The following is a description of a gene set: Any process that modulates the frequency, rate or extent of bone mineralization. species: Homo sapiens Human Gene Set: GOBP_REGULATION_OF_BONE_MINERALIZATION, and this is the list of marker genes: FAM20C, TXLNG, COMP, FBN2 (fibrillin 2), VDR, WNT4, PTN, ACVR2B, TMEM119, OSR1, ACVR2A, SRGN, PTH, NOTUM, BMP6, STATH, ACTN3, TRPM4, BMP2K, CCR1, GPM6B, GATA1, TWIST1, NELL1, BCOR (NCBI Gene Id 57686), ADGRG6, TFAP2A, ATP2B1, S1PR1, ATRAID, OSR2, KL, P2RX7, ANO6, BMP4, SOX9, ADGRV1, CCN1, SUV39H1, BMPR1A, GREM1, RFLNA, PHOSPHO1 (phosphoethanolamine/phosphocholine phosphatase 1), BGLAP, PKDCC, RFLNB, HIF1A, NBR1, SLC8A1, BMPR2, AHSG, BMPR1B, CYP27B1, RXRB, ZMPSTE24 (zinc metallopeptidase STE24), SGMS2, ISG15, IFITM5, MGP, ECM1, SMAD3, ALOX5, PTK2B, LTBP3 (NCBI Gene Id 4054), ADRB2, ANKH, DDR2, MEF2C, LTF, BMP2, SLC20A2, WNT10B, MATN1, FGF23, FZD9, CCL3, ACVR1, RXRA, ENPP1, TENT5A, BMP7, MIR208A